Given this list of marker genes Timm44, Ywhae, Atf2, Camsap3, Psap, Mpdz, Ergic3, Unc93b1, Fam53b, Lmna, Ubr5, Stx3, Scfd2, Ap3d1, Ap2a1, Nsg1, Myo5a, Vps36, Smo, Arfrp1, Ptpn23, Heatr3, Syndig1, Sec23b, Tomm20l, Acd, Nup93, Kif20b, Ehd1 (NCBI Gene Id 13660), Stx11, Snx16, Il33, Ap1s1, Oaz3, Vps26b, Ctdspl2, Rab10 (NCBI Gene Id 19325), Tmed1, Vcp, Cltc, Syvn1, Gga1, Stx8 (NCBI Gene Id 80802), Snx1, Tecpr2, Ifi27, Vps8, Pex10, Elavl1, Flna (filamin, alpha), Slu7, Notch1, Snx13, Jak2, Tmem30a, Gripap1, Cd36, Pex3, Timm9, Prkcd, Kcnq3, Pex13, Vti1b, Klc1, Nup88, Zic1, Arl5b, Myo5b, Herpud1, Ngfr, Kpna1, Kif3a, Epm2a, Uso1, Trim23, Ap2b1, Gga2, Ndel1, Vps33a, Chrm1, Nploc4, Chp1, Tmed2, Chml, Phip, Ift22 (intraflagellar transport 22), Dmap1, Ap1s2, Vps29, Rab1b (RAB1B, member RAS oncogene family), Myo7a, Rbm22, Mdm2, Arl5c, Pttg1ip, Aup1, Arl6, Laptm5, Akap5, Arl4d, Sec24a, Bmp2, Pex6, Arl4c, Chp2, Ptpn14, Grip2, Selenos, Rab29, Adipoq, Vps33b (NCBI Gene Id 233405), Tmed3, Rab21, Pex12, Xpo4, Kif1a, Vps26a, Ran, Ift27, Rab8b, Stx2, Sar1a, Ipo5, Lrrk2, Edem1, Rims2, Romo1, Ing1, Arl5a, Tsc2, Arf2, Cd81, Ube2g2, Pex7, Timm13, Rab24, Akap1, Grip1, Prr5l, Pex5, Rftn1, Stx17, Edem2, Bmpr1a, Xpo6, Sprn, Angpt1, Slc35d3, Ranbp2, Nup35, Wipf1, Rab5c, Arhgap44, Ei24, Becn1, Tek, Pex1, Vps25, Bard1, Fam76b, Ubac2, B3gat3, Ndp, Nr4a1, Cse1l, Rims1, Ipo8, Anp32b, Bcap31, Stx1b, Fgf9, Rab13, Irgm2, Snx8, Zdhhc2, Ipo4, Mtch2, Tamalin, Ap3b1, Cdc42 (cell division cycle 42), Rab20, Rffl, Ube2j1, Myrip, Txn1, Napg, Copb2, Gfap, Snx2, Rab32, Srp54a, Sp100, Prpf4b, Stx6, Stx16, Neto1, Pik3c3, Mon1b, Cd74, Rasl2-9, E2f3, Akirin2 (NCBI Gene Id 67185), Copg2 (coatomer protein complex, subunit gamma 2), Sumo1, Timm23, Rab6a, Trarg1, Ddx5, Samm50, Tuba1a, Snx17, Vps45, Rilpl1, Zfyve16, Rapgef3, Stxbp1, Ap2a2, Srp54c, Kpna2rt, Ipo11 (importin 11), Egr2, Vps28 (vacuolar protein sorting 28), Gbp4, Rab23, Gcc2, Scrib, Afg2b, Tmco6, Clta, Rab17, Desi1, Nup155, Hgs, Vipas39, Psen1, Hsp90ab1, Cep131, Nutf2-ps2, Snx27, Faf2, Derl3, Nup50, Rabl2, Lep, Rabl3, Hdac3, Nedd4, Tmed5, Nsf, Pex16, Trim37, Pdcd10, Scamp3, Traf3ip2, Stradb, Stx1a, Tram2, Snx3, Stk4, Ywhab, Ap1s3, Hikeshi, Eif4enif1, Tgfb1, Sorcs2, Pkia, Uhmk1, Sytl4, Kif13a, Nup214, Ufm1, Park7 (Parkinson disease (autosomal recessive, early onset) 7), Rhbdd1, Pick1, Jup, Napb, Sort1, Stxbp3, Kpna2, Ranbp17, Pex5l, Tmem30b, Pdcd5-ps, Vamp2, Gpihbp1, Usp9x, Cry2, Cdk1, Rph3al, Wls, Sorl1, Tmed10, Abca12, Sec61a2 (NCBI Gene Id 57743), Peg12, Tenm1, Timm22, Gli3, Copb1, Lyset (lysosomal enzyme trafficking factor), Ptpn1, Tmed7, Xpo1, Xbp1, Mia2, Cog3, Tnpo1, Tmed11, Commd1, Nos3, Pkig, Nup50l, Rab7, Srpra, Sfn, Bag3, Stx4a, Ap4s1, Sar1b, Sytl1, Cdkn1a, Snf8, Ap3m1, Mapk14, Rilpl2, Clip1, Bcap29, Appbp2, Agk, Tomm22, Ap5z1, Stx12, Prkd1, Nfkbia, Hspa5, Ect2, Atp13a2, Steep1, Kpna4, Hspb1, Sec61bl, Pkd1, Mapk1, Ptpn22, Tnfrsf1a, Ipo7, Rab11a, Brca1, Vps18, Erlec1, Pcnt, Sec63, Arfip2, Fam53a, Rab38, Trmt10b, Irgm1, Vps37a, Smurf1, Svip, Scfd1, Nf1 (neurofibromin 1), Dctn1, Hyal2, Nup107, Tram1l1, Derl1, Snx31, Sec16b, Six2, Pex2, Sec23a, Glp1r (NCBI Gene Id 14652), Ywhah, Ap1g2, Ipo13 (importin 13), Exph5, Pdcd6, Copg1, Sec62, Rufy3, Ndufa13, Bmpr2, Pik3r1, Pik3r4, Fam91a1, Ap2m1, Stat3, Sel1l, Rab22a, Agtr2, Tmem129 (NCBI Gene Id 69753), Timm29, Prkaca, Fam53c, Rab1a, Gckr, Syk, Bcr, Grk3, H13, Ranbp3, Clu (clusterin), Nup58, Vps13c, Rab8a (RAB8A, member RAS oncogene family), Kpna7, Pom121l2, Washc1, Gper1, Arfip1, Nup54, Tlk1, Rab31, Atp6ap1, Vps26c, Vps35, Cdkn2a, Nutf2-ps1, Itgb1, Gnptab, Dlg2, Rhob, Tardbp (TAR DNA binding protein), Clip3, Scg5, Eif3e, Uaca, Ptgs2, Ncoa4, Ap3b2, Cog7, Pttg1ip2, Ap4b1, Zpr1, Igtp, Hsp90aa1, Cltb, Rangrf, Os9, Tram1, Cep290, Lrrc7, Sytl2, Ap4m1, Sirt6, Hm629797, Gsk3b, Ifng, Rab5b, Asph, Dyrk1a, Wdr11, Pml, Stx5a, Umod, Yod1, Apod, Copz2, Snx33, Vps16, Dnajc27, Pex19 (peroxisomal biogenesis factor 19), Zfand1, Insig1, Spg11, Ap3s1 (NCBI Gene Id 11777), Tnpo2, Sec16a, Hdac6, Ripor1, Mdfic, Pcm1, Sirt7, Nutf2, Vps39, Pola2, Gas6, Nup62cl, Stxbp2, Snupn, Akt1, Xpot, Nup133, Fermt1, Calr, Mon1a, Cdh1, Arf4, Pom121, Stx19, Ep300, Shh, Rab43, Camk4, Vps11, Trim28, Kcnip3, Xpo7, Arl1, Gga3, Stk3, Ric1, Ap2s1 (adaptor-related protein complex 2, sigma 1 subunit), Spag17, Stx18, Tmed6, Rab2a, Derl2, Ap1m2, Atg14, Timm10, Kif5a, Ramp2, Six3, Arf1, Cdk5, Arf3, Efcab7, Kif5c, Pik3r2, Tnpo3, Ankle1, Vps53, Hnf4a, Snx5, Tmed9, Camk1, Nup62, Med1, Trp53, Lcp1, Cchcr1, Il6, 5730455P16Rik, Ranbp3l, Rab28, Ice1, Txnip, Exoc6, Snx10, Exoc6b, Mmp12, Sec13, Xpo5, Cfl1, Snapin, Tmed10-ps, Tmed4, Prkcq, Cd24a, Septin8, Emd, Pdcd5, Rab27b, Tbc1d13, Pex14, Mavs, Lonp2 (lon peptidase 2, peroxisomal), Mapk8ip3, Rangap1, Lamp2, Slc51b, Nfatc3, Napa, Ranbp6, Prickle1, Sqstm1, Apba1, Ap1m1, Lhcgr, 1700009N14Rik, Ppp3ca, Tm9sf4, Reep2, Bmp4, Sec61a1, Plk3, Appl1, Appl2, Stx7, Agt, Arl4a, Kpnb1, Arf6, C2cd5, Arl14, Ufd1, Sytl3, Nup85, Kpna3, Vps41, Ap3m2, Pex26, Chchd4, Ap3s2, Vps13a, Gm14461, Tpr, Copa, Hspa8, Vps13d, Nxt1, Rab18, Strada, Oaz1, Kpna6, Ptpn5, Snx11, Bmal1, Scarb2, Abra, Map1a, Ppm1a, Hcls1, Vps37b, Zc3h12a, Vps54, Vps4a, Hspa9, Tgfbrap1, Drd1, Marcks, Rtn2, Agap3, Frat1, Nolc1, Ahcyl1, Aspscr1, Oaz2, Rab5a, Tomm70a, Large1, Sec61b, Ptpn11, Phb2, Rab19, Copz1, Vps37c, Nup153, Vps37d, Vti1a, Ap1g1, Tomm20, Nup188, Sec61g, Hsp90b1, Zfand2b, Ppp3r1, Nup98, Rab14, Stam, Bcl3, Ramp1, Mlph, Ap1b1, Hspa4, Sh3tc2, Cwh43, Adar, Cabp1, Snx6, M6pr, Arl11, Cttn, Rpain, Ap4e1, Kif5b, Sytl5, Arf5, Kcnq2, Frat2, Ramp3, Mtch1, Ipo9, Snx9, Rph3a, Chm, Rab6b, here is a description of the gene set: Mouse Gene Set: GOBP_INTRACELLULAR_PROTEIN_TRANSPORT The directed movement of proteins in a cell, including the movement of proteins between specific compartments or structures within a cell, such as organelles of a eukaryotic cell. species: Mus musculus